The following is a description of a gene set: Understanding the response of memory CD8 T cells to persistent antigen re-stimulation and the role of CD4 T cell help is critical to the design of successful vaccines for chronic diseases. However, studies comparing the protective abilities and qualities of memory and naïve cells have been mostly performed in acute infections, and little is known about their roles during chronic infections. Herein, we show that memory cells dominate over naïve cells and are protective when present in large enough numbers to quickly reduce infection. In contrast, when infection is not rapidly reduced, memory cells are quickly lost, unlike naïve cells. This loss of memory cells is due to (i) an early block in cell proliferation, (ii) selective regulation by the inhibitory receptor 2B4, and (iii) increased reliance on CD4 T cell help. These findings have important implications towards the design of T cell vaccines against chronic infections and tumors. species: Homo sapiens from publication West EE, Youngblood B, Tan WG, Jin HT, Araki K, Alexe G, Konieczny BT, Calpe S, Freeman GJ, Terhorst C, Haining WN, Ahmed R (PMID 21856186) Human Gene Set: GSE30962_ACUTE_VS_CHRONIC_LCMV_PRIMARY_INF_CD8_TCELL_UP Genes up-regulated in comparison of splenic primary CD8 effector T cells at day 8 post-acute infection versus splenic primary CD8 effector T cells at day 8 post-chronic infection., and this is the list of marker genes: CEP97, ARL4C, ACSS2, MXD4, YPEL5, CHD7, LCK, NR1D2, TP53INP1, SELPLG, ORAI2, TRAF3IP1, ESM1, TECPR1, RASL12, MFNG, CYB561A3, JAK1, CMA1, FCGR2B, KCNJ8 (NCBI Gene Id 3764), ITGB2, CDHR1, SFXN3, STMP1, GZMA, PRR13, TNIP1, BCL11B, KLF2, LETM2, CDKN1B, PCMTD2, VSIR, SESN1, FBRS, SEMA4F, YES1, ARHGEF2, TYK2, FCGRT, STAT6, ZBTB9, EMP1, PHF21B, B4GALT1, LRRC24, PRKX, FAM117A, PIK3R5, RRAS, CX3CR1, EVA1B, EVL (NCBI Gene Id 51466), IL18RAP, P3H4, NHSL2, ABCG1, GALNT10, PHF21A, PRKD2, INSL6, UBE2H, SUN2, GNS, SLCO3A1, CPM, S1PR5, RASAL3, NHERF1, RAP2A, PXYLP1, YPEL3, HLA-A, NCALD, CCR2, GPX8 (glutathione peroxidase 8 (putative)), STK38, LIMD1, GABARAPL2, AP3M2, FAM78A, RAP1B, TXNDC5, PDCD6IP, AS3MT, RARA, BORCS7, IFNAR2, RNF13, SLC2A3, KDM7A, HOPX, PEA15, ARMC7, MRTFA, HSPH1, PDLIM1, DOCK5, BCL9L, FHIP1B, ADRB2, PPP3CA, ID2, GAB3, ACSS1, BNIPL, KLF3, KLRG1, ARHGAP25, VCF1 (VCP nuclear cofactor family member 1), NOD1, IQGAP2, G0S2, SMAD3, ADGRE5, TMEM131L, LTB, ICAM1, SMOX, PPP2R5A, ACTN2, DTX1, BNIP3L, L3MBTL3, KCTD2, PEAK1, PRKAB2, RFX3, IL11RA, VWA1, COX7A2L, MAML2, CD96, AQP9, SLC37A1, ST8SIA1, PGM2L1, BRWD1, SELENOP, LINC01160, RFX1, CARD6, ENTREP3, ANTXR2, KRI1, RAP1GAP2, CREBRF, HDHD5, APBB1IP, TTC39C, SLC12A7, TBX21, ARL2BP, C1orf21, METTL23, ZEB2, LPAR6, STX17, ARL6IP5, FIRRE, TRIM65, CACNA2D4, FGF13, SYF2, TXNIP, RSU1, KRTCAP2, KIF21B, GRAMD2B, ABCA6, ENSG00000286190, MPND (MPN domain containing), ARHGAP45, WFIKKN2, TSPAN5, ANXA4, PBXIP1, GTF2I, PNPLA7, NCK2, TKTL1, RASGRP1, TNFAIP8L2, PIGB, GZMM, IP6K1, SLC20A1, PHF13, SGK1 (serum/glucocorticoid regulated kinase 1), PLCG1 (phospholipase C gamma 1), SBK1, IER5, ZNF652, UCKL1, DNAJC15, RERE, ATP2A3, ANKRD11, TOB1